Given this list of marker genes NR4A3, CREB3L2, HMGA2, JDP2, TCF12, ATF7, ATF2, CREB5, JUN, E4F1, CREB3L1, CREB1, here is a description of the gene set: species: Homo sapiens Human Gene Set: GOMF_CAMP_RESPONSE_ELEMENT_BINDING Binding to a cyclic AMP response element (CRE), a short palindrome-containing sequence found in the promoters of genes whose expression is regulated in response to cyclic AMP.